Given this list of marker genes Cyp7b1, Cyp3a44, Cyp1a2, Cyp11b1, Cyp1b1, Cyp39a1, Cyp2b13, Cyp46a1, Cyp3a57, Cyp21a1, Cyp2b9, Cyp2u1, Cyp2c39, Cyp2d22, Cyp3a16, Cyp2c65, Cyp2c29, Cyp11b2, Cyp2c66, Cyp17a1 (NCBI Gene Id 13074), Cyp2b23, Cyp24a1, Cyp7a1, Cyp1a1, Ch25h, Cyp3a41b, Cyp3a25, Cyp2b10, Cyp27a1, Cyp2a22, Cyp3a13, Cyp11a1, Cyp2a12, Fdx1, Cyp2c50, Cyp2b19, Cyp2c38, Cyp8b1, Cyp19a1, Cyp2r1, Cyp3a41a, Cyp3a11, Cyp3a59, Cyp2c37, here is a description of the gene set: Catalysis of the formation of a hydroxyl group on a steroid by incorporation of oxygen from O2. Mouse Gene Set: GOMF_STEROID_HYDROXYLASE_ACTIVITY studied in species Mus musculus